Given this list of marker genes COL5A1, FERMT2, HBEGF, FIGNL2, WNT7A, CLASP1, ITGB1, ITGAV, MEGF8, LCP1, RHOA (ras homolog family member A), AJUBA, PDPN, ARHGAP24, ACVRL1, MSX2, DDR1, PHLDB2, CARMIL2, CEACAM1, MRTFA, ARHGAP35, CD151, ITGA5, PLET1, FERMT1, LRG1, MIR221, MMP12, RREB1, TMEFF2, TOR1A, ITGB3, PTEN, CLASP2, MTOR, PDCD10, ADAM17, HTN1, CD44, ITGB5, RHOC, FLNA, here is a description of the gene set: Human Gene Set: GOBP_EPIBOLY species: Homo sapiens The expansion of one cell sheet over other cells or yolk.